Given this list of marker genes Slc24a2, Slc24a5, Slc24a4, Slc24a3, Slc24a1, here is a description of the gene set: Enables the transfer of a solute or solutes from one side of a membrane to the other according to the reaction: Ca2+(in) + K+(in) + Na+(out) = Ca2+(out) + K+(out) + Na+(in). species: Mus musculus Mouse Gene Set: GOMF_CALCIUM_POTASSIUM_SODIUM_ANTIPORTER_ACTIVITY